Given this list of marker genes RNF113A, GTF2E2, ERCC5, ERCC4, AARS1, TARS1, CARS1, MPLKIP, MITF, ERCC2, ERCC3, GTF2H5, here is a description of the gene set: species: Homo sapiens Numerous pigmented freckles Human Gene Set: HP_NUMEROUS_PIGMENTED_FRECKLES